Given this list of marker genes FLOT1, SLC6A3, CBL, CTNNA1, FLOT2, CORO1C (coronin 1C), CDH1, CTNNB1, SORBS1, here is a description of the gene set: A protein complex that contains flotillin-1 and flotillin-2, and may contain associated proteins. Flotillins associate into membrane microdomains resembling caveolae. species: Homo sapiens Human Gene Set: GOCC_FLOTILLIN_COMPLEX